Given this list of marker genes NR3C1, CSF1R, NOG, EZR, BTRC, FRS2, MMP2, CEBPB, WNT4, WNT3A, DDR1, TBX2, NFIB, KDM5B, EGFR, LRP5, CSMD1, GDF7, SERPINB5, TGFBR2, BMP4, FGL1, NOTCH1, HOXA13, CAPN1, CRIP1, FGFR1, TWSG1, RARG, TGFA, SNAI2, CCL11, BCL2, PGR, TGFB1, XBP1, NRP1, IGFBP5, PDGFA, SEMA3C, PML, ETV5, TGM2, MSX2, SFRP1, BTBD7, PTN, SULF1, CUL3, NKX3-1, CYP7B1, TNF, MSN, CEACAM1, IL6, STAT5A, BAX, BMP7, SOSTDC1, GLI1, FGF8, POLB, PROP1, TNC (tenascin C), CSF1, HGF, MDK, RTN4, LIPA, AREG, BSX, AR (androgen receptor), NRG3, FGF7, DAG1, PLXNA1, LAMA1, RPS6KA1, IGF1, SRC, TNFAIP3, TBX3, ELF3, WNT5A, TP63, TFAP2C, CAV1, PTCH1, FGF10, CDKN2A, MED1, PLAG1, EDAR, NTN4, PAX6, CFLAR, VDR, HOXD13, TGFB2, TGFB3, FGFR2, STAT6, FBXW7, SOX9 (NCBI Gene Id 6662), EPHA2, LAMA5, SULF2, NFKB1, HOXB13, PROX1, ID4, GLI3 (GLI family zinc finger 3), NTN1, PHB2, SHH, EDA, NKX2-3, RXFP1, SCRIB, PERP, HPN, FOXA1, PLXND1, FEM1B, CAV3, LIMS2, NHERF1, ESR1, NOTCH2, ESRP2, here is a description of the gene set: studied in species Homo sapiens Human Gene Set: GOBP_GLAND_MORPHOGENESIS The process in which the anatomical structures of a gland are generated and organized.